Given this list of marker genes Mgst3, Ltc4s, Mgst2, Gstm4, Alox5ap, here is a description of the gene set: Mouse Gene Set: GOMF_LEUKOTRIENE_C4_SYNTHASE_ACTIVITY studied in species Mus musculus Catalysis of the reaction: leukotriene C(4) = glutathione + leukotriene A(4).